Given this list of marker genes TUBB2B, GUCY2D, RPGRIP1 (NCBI Gene Id 57096), PCYT1A, USP45, TUBA1A, PRPS1 (NCBI Gene Id 8254), RDH12, CRX, LRAT, SH3TC2, PMP22, TULP1, PHOX2A, CEP290, RPE65, PSAP, CNGB3, COL25A1, NMNAT1, CHRNA3, AIMP1, KCNJ13, GDF6, KIF21A, IQCB1, LCA5 (lebercilin LCA5), MPZ, CNGA3, GNAT2, SPATA7, PDE6C, GALC, CHRM3, IMPDH1, COL18A1, LAMB2, TUBB4B, COLQ, RPGR, PDE6H, CRB1, AIPL1, TUBB3, RD3, ATF6, IFT140, here is a description of the gene set: An abnormality of the reflex that controls the diameter of the pupil, in response to the intensity of light that falls on the retina of the eye. Human Gene Set: HP_ABNORMAL_PUPILLARY_LIGHT_REFLEX Abnormal pupillary light reflex studied in species Homo sapiens